The following is a description of a gene set: Pancreatic islet-cell hyperplasia studied in species Homo sapiens Human Gene Set: HP_PANCREATIC_ISLET_CELL_HYPERPLASIA Hyperplasia of the islets of Langerhans, i.e., of the regions of the pancreas that contain its endocrine cells., and this is the list of marker genes: DIS3L2, UCP2, KCNJ11, FAH, INSR, ABCC8, HNF4A, GCGR, SLC16A1, GPC4, GPC3, LBR